Given this list of marker genes ZBP1, DOCK2, CD164, CNP, SH2D1A, LPAR6, TOR3A, PCMTD1, OXR1, SLC35G1 (solute carrier family 35 member G1), MYO6, MARCHF6, IL17RA, PDE2A, CMIP, GNG2, SLC20A1, DEXI, CREBRF, ALKBH4, PRKCA, NRROS, SPO11, SMAD7, LAT (NCBI Gene Id 27040), EHD3, C6orf118, TMEM123, PTEN, GRINA, BCL2, IRAK3, POU6F1, LIMD1, RNF111, IER3, EZH1, GMFG, SLAMF6, MFNG, DGKA, ELF1, SSH2, CDKN1B, ETNK1, PRAMEF8, IL4R, TNFRSF9, WASHC4, DGKD, TTYH3, OSBPL3, SELENOO, F2RL1, FBXO33, NXPE3, ATG13, RNF146, MAT2B, IL18RAP, YPEL3, ADAMTSL4, SLC4A7, CCNI, TSR1, GZMH, RCN1, BTG3, RABAC1, TAB2, PHAF1, NRIP1, TNFRSF25, CCND2, SLAMF1, INPP1, STK17B, ULK1, UBE2H, NIPAL1, ITGA7, VPS54, RETREG3, CPE, RNF19A, AKAP8L, ST8SIA6, SARAF, KBTBD11, SLC2A3, LIME1, GNS, SLC9A9, SPNS1, TGIF1, IDNK, ATP1A1, CYTIP, STING1 (NCBI Gene Id 340061), RAB21, EIF3F (NCBI Gene Id 8665), RUNDC1, S100A4, GADD45G (growth arrest and DNA damage inducible gamma), TRIM25, ITK, TRIM34, PELI1, MBD2, DEGS1, AFF3, SELENOS, STT3B, PIK3C2A, MFSD6, MPPE1, SNX14, NSD3, GIMAP4, SELENOT, UBAC2, PDLIM1, PPP3CA, RIOK3, HS3ST3B1, IL15RA, HACD3, ETV3, EIF2AK1, RRAGD, STK38 (NCBI Gene Id 11329), PNRC1, SLC25A45, SELL, LGALS3BP, FBXO32, CD274, TRPC4AP, PPM1K (NCBI Gene Id 152926), UBASH3B, PRKACB, ABTB1, AHCYL2 (NCBI Gene Id 23382), TENT5A, FAM32A, ITPKB, CD53, CD96, BTG2, CHMP1B, UTRN, S1PR4, NFRKB, DYRK2, LIPA, UPF2, EGR1, CPM, CRLF3, KLF13, PCMTD2, CD8B (CD8 subunit beta), SLC41A1, ARIH2, STX16, FAM8A1, HLA-G, DALRD3 (DALR anticodon binding domain containing 3), PLCG2, FOXP1 (forkhead box P1), AKAP13, IRF9 (NCBI Gene Id 10379), PPP1R3C, RBM33, EPSTI1, ZYG11B, OSM, PPP1R12A, ENTPD5, KIDINS220, PARP14, CD200, SIDT2, RIPOR2, ALKBH1, ANKH, AFF4, NFKBIE, JUN, TRIM56, STIM2, ZBTB2, TRIM21, MAML1, SUN2, UGGT1, ORAI2 (ORAI calcium release-activated calcium modulator 2), KLRC1, IL1RL1, C14orf119, here is a description of the gene set: studied in species Homo sapiens Human Gene Set: GSE22601_DOUBLE_POSITIVE_VS_CD8_SINGLE_POSITIVE_THYMOCYTE_UP from publication Dik WA, Pike-Overzet K, Weerkamp F, de Ridder D, de Haas EF, Baert MR, van der Spek P, Koster EE, Reinders MJ, van Dongen JJ, Langerak AW, Staal FJ (PMID 15928199) Genes up-regulated in thymocytes: double positive versus CD8 single positive. T cells develop from progenitors that migrate from the bone marrow into the thymus. Thymocytes are subdivided roughly as being double negative (DN), double positive (DP), or single positive (SP), based on the expression of the CD4 and CD8 coreceptors. The DN stage is heterogeneous and can be subdivided into four distinct subsets in mice based on the expression of CD44 and CD25. In human, three distinct DN stages can be recognized: a CD34+CD38−CD1a− stage that represents the most immature thymic subset and the consecutive CD34+CD38+CD1a− and CD34+CD38+CD1a+ stages. Human DN thymocytes mature via an immature single positive (ISP CD4+) and a DP stage into CD4+ or CD8+ SP T cells that express functional T cell receptors (TCR) and that exit the thymus. In this study, gene expression was measured in each of these nine stages.